Given this list of marker genes PAGE4, LGALS14, PSG3, PSG5, CRIM1, CSH1, S100A10 (S100 calcium binding protein A10), PSG7, EBI3, IGFBP1, KISS1, VGLL1, PSG9, PSG2, MAFF, LEP, RHOBTB1, GDF15, PSG1, PLAC1, GCM1, HSD3B1, EGFL6, MMP11, PAPPA, PAPPA2, TFAP2A, CRH, SEMA3B, GH2, AOC1, CAPN6, ALPP, HSD17B1, PSG6, ADAM12, SVEP1, INSL4, MAN1C1, TIMP2, CYP19A1, PSG4, here is a description of the gene set: Neighborhood of MMP11 species: Homo sapiens Human Gene Set: GNF2_MMP11 Neighborhood of MMP11 matrix metallopeptidase 11 (stromelysin 3) in the GNF2 expression compendium